Given this list of marker genes STUB1, LONRF1, COQ3, NDUFAF4, RRP8, CLPX, MTHFD2, NOL12, LIG3, CHAMP1, PPP1R7, PHF10, BBS12, LRRC59, TSR2, HMBS, POP1, KICS2, ZMPSTE24, EIF4A3, RPN2, CISD2, TAF10, NAF1, PIGL, HSPA4, RPS19BP1, UBXN8, AP1G1, COQ4, SPCS3, ILF3, CXCL10, PRDX3, TRIP13, SHMT2, NIP7, CMTR2, CUL2, TSR1, STX6, NUDC, BABAM2, TMEM160, BAG1, SPCS1, NUTF2, SLC7A5, NUP205, SENP3, ERH, PGAM1, KLHDC4, NUP35, GARS1, GFER, CHAC2, SLC25A39, EIF4E, MTNAP1 (NCBI Gene Id 55028), RBM17, QTRT1, GNPNAT1, DOHH, DDX1, ABHD11, RPP40, NUP54, PMPCB, PRELID3B, CEBPG, AP1AR, CAD, PIN1, MRPL15, PDIA6, GEMIN6, WDR3, SLC25A6, WDR36, NLE1, SMYD5, POGLUT2, PPP1R14B, WDR73, C1QBP, REXO2 (NCBI Gene Id 51640), IMP4, NOP56, ZPR1, EXOSC1, BUB3, NAA20, EIF5A2, ZNF22, TUBB4B, NPM1, TANC2, MRPL35, RWDD2B, NUP107, GEMIN5, UQCR11, ACBD6, EGR2, POLE4, ATP23, PSMG2, EXOSC5, PDSS1, PREP, NOP16, TMEM97, EIF5B, LCMT2, PCNA, TRNAU1AP, NARS2, TARS1, TMEM80, CAPSL, TBL3, NDUFS5, NOB1, PHGDH, PCMT1, AHR, UTP11, UTP15, YARS1, TRMT10C, SLC25A33, IMMT, TSNAX, C7orf25, ATP6V1C1, AHCYL1, MRPL47, GLRX5, DDX51, RPP30, PTPN2, GGH, SRM, AAMP, SPP1, EPRS1, ETF1, GPN1, SF3A3, TEFM, SERPINB2, PIN4, CRELD2, CCDC90B, PHB1, BMI1, NUP43, GTF2H2 (general transcription factor IIH subunit 2), NVL, ZBTB1, APRT, AARS1, GTF2F2, GRN, CNOT9, JAGN1, ABCC4, PSMG4, MDH2, NOL11, RRS1, IL4I1, FEM1B, TPD52L2, ODC1, PLPP1, DARS1, SET, JADE3, IARS1, CHCHD4, NOP2 (NOP2 nucleolar protein), SURF2, TUBB6, MMGT1, POLD2, ACOT7, NAA15 (N-alpha-acetyltransferase 15, NatA auxiliary subunit), SRSF3, C5orf15, CHML, ADSS2, SIGMAR1, RWDD4, YBX1, NARS1, PSMB6, DNMT3B, PPIF, here is a description of the gene set: Human Gene Set: GSE22432_MULTIPOTENT_VS_COMMON_DC_PROGENITOR_UNTREATED_UP Genes up-regulated in amplified multipotent progenitors versus cultured untreated common dendritic cell progenitors. Dendritic cells (DCs) in lymphoid tissue comprise conventional DCs (cDCs) and plasmacytoid DCs (pDCs) that develop from common DC progenitors (CDPs). CDPs are Flt3+c-kitintM-CSFR+ and reside in bone marrow. Here we describe a two-step culture system that recapitulates DC development from c-kithiFlt3-/lo multipotent progenitors (MPPs) into CDPs and further into cDC and pDC subsets. MPPs and CDPs are amplified in vitro with Flt3 ligand, stem cell factor, hyper-IL-6 and insulin- like growth factor-1. The four-factor cocktail readily induces self-renewal of MPPs and their progression into CDPs and has no self-renewal activity on CDPs. The amplified CDPs respond to all known DC poietins and generate all lymphoid tissue DCs in vivo and in vitro. Additionally, in vitro CDPs recapitulate the cell surface marker and gene expression profile of in vivo CDPs and possess a DC-primed transcription profile. Transforming growth factor-β1 (TGF-β1) impacts on CDPs and directs their differentiation towards cDCs. Genome-wide gene expression profiling of TGF-β1-induced genes identified transcription factors, such as interferon regulatory factor-4 (IRF-4) and RelB, that are implicated as instructive factors for cDC subset specification. TGF-β1 also induced the transcription factor inhibitor of differentiation/DNA binding 2 (Id2) that suppresses pDC development. Thus, TGF-β1 directs CDP differentiation into cDC by inducing both cDC instructive factors and pDC inhibitory factors. from publication Felker P, Seré K, Lin Q, Becker C, Hristov M, Hieronymus T, Zenke M (PMID 20881193) species: Homo sapiens